Given this list of marker genes CLSPN, H2AC6, IL17RB, WWC1, GORAB, PWWP2A, LIG4, MT1X, PTEN, TIMD4, KDSR, COG6, RGCC (regulator of cell cycle), BHLHE40, CCN2, HSD17B4, PICALM, HADH, here is a description of the gene set: Werner syndrome (WS) is a premature aging disorder, displaying defects in DNA replication, recombination, repair, and transcription. It has been hypothesized that several WS phenotypes are secondary consequences of aberrant gene expression and that a transcription defect may be crucial to the development of the syndrome. We used cDNA microarrays to characterize the expression of genes and ESTs across a panel of 15 primary human fibroblast cell lines derived from young donors, old donors, and WS patients. Of the analyzed genes, 6.3% displayed significant differences in expression when either WS or old donor cells were compared with young donor cells. This result demonstrates that the WS transcription defect is specific to certain genes. Transcription alterations in WS were strikingly similar to those in normal aging: 91% of annotated genes displayed similar expression changes in WS and in normal aging, 3% were unique to WS, and 6% were unique to normal aging. We propose that a defect in the transcription of the genes as identified in this study could produce many of the complex clinical features of WS. The remarkable similarity between WS and normal aging suggests that WS causes the acceleration of a normal aging mechanism. This finding supports the use of WS as an aging model and implies that the transcription alterations common to WS and normal aging represent general events in the aging process. Human Gene Set: KYNG_NORMAL_AGING_DN species: Homo sapiens from publication Kyng KJ, May A, Kølvraa S, Bohr VA (PMID 14527998) Genes distinctly down-regulated in primary fibroblast cultures from normal old donors compared to those from normal young donors.